The following is a description of a gene set: Human Gene Set: HP_INCREASED_URINARY_PORPHOBILINOGEN The concentration of porphobilinogen in the urine, normalized for urine concentration, is above the upper limit of normal. species: Homo sapiens Increased urinary porphobilinogen, and this is the list of marker genes: UROS, HMBS, GATA1, ALAD, CPOX, PPOX